The following is a description of a gene set: Cell cycle genes with peak expression in G2/M check point. Cell cycle genes with a CC Expression Score >= 2 (identified in at least 2 genome-wide cell cycle gene expression profiles with peak expression in G2/M) Human Gene Set: FISCHER_G2_M_CELL_CYCLE from publication Fischer M, Grossmann P, Padi M, DeCaprio JA (PMID 27280975) species: Homo sapiens, and this is the list of marker genes: NUSAP1, SLCO1B3, EIF4E, TDP1, TACC3, MID1, KIF18B, H2AZ2, MKI67, CENPL, ADGRG6, UBE2C, MTMR6, CDKN2D, ECT2, SMTN, TNFAIP8L1, CKAP2L, NUP37, SPAG5, POLQ, CDCA2, TTF2, CYP1A1, BCAR3, CENPE, SLC25A24, HMGB2, BRD8, CCNA2, CSPG4, CCNB2, SERTAD3, PPP2R5C, SPA17 (NCBI Gene Id 90953), ARHGEF39, RIN2, GAS2L3, BUB3, CTNND1, CEMIP (cell migration inducing hyaluronidase 1), CIT, KMT5B, TGIF1, NUP98 (NCBI Gene Id 51457), CDR2, PRC1 (NCBI Gene Id 9055), CNTROB, RACGAP1, GIT2, MEAK7, TMPO, CDC25B, BAG3, H2AX, CDC27, CCSAP, TNFAIP2, CFLAR, HMMR, TRIM59, ANP32E, ELK3, KIF2C, DCP2, ARL6IP1, WSB1, AMD1, CDKL5, NUP50, HMGA2, TJP1, CDKN2C (NCBI Gene Id 654235), MAT2A, TSN, DEPDC1 (NCBI Gene Id 55635), KNSTRN, HMG20B (high mobility group 20B), CKAP2, RGS3, KDM6A, JADE2, WEE1, ZNF207, ESPL1, NDC80, PPP1R10, KIF22, TRIP13, HSPA1L, TGFB2, LAMC1, PLK4, BUB1, ZNF587, BMP2, METTL4 (NCBI Gene Id 64863), FAM83D, KCTD9, DZIP3, NEDD4L, RAD21, KIF20B, PNRC2, SAPCD2, STK17B, KIF18A, GPSM2, TTK, TNFRSF21, ADGRE5, ACSL4, ANXA3, FZR1, DBF4B, OIP5, NUMB, CDK1, HJURP, KIF23, TOP2A, UBE2G1, AURKA, PSMD11, KIF11, PLK1, LBR, TROAP, DUSP4, RNF4, TNPO2, CCNF (NCBI Gene Id 899), RDH11, PTTG1, PLAU, GTSE1, DCLRE1C, KIF14, SFPQ, KIF20A (kinesin family member 20A), BIRC5, PBK, TUBD1, BTBD3, CEP350, KATNA1, DNAJB1, ARHGAP11B, SHCBP1, ATF7IP, ARHGAP11A, MELK, PCF11, NIF3L1, FAM110A, KIF5B, CDCA3, CKS2, CDC42EP4, NEIL3, DEPDC1B (DEP domain containing 1B), PLEKHA5, NUF2, CDC20, IQGAP3 (IQ motif containing GTPase activating protein 3), HMGCR, SIX4, NCAPH, CENPA, HP1BP3, EIF2AK3, MPHOSPH9, DR1, PSRC1, VANGL1, FOXM1, GOT1, ZNF614, CEP55, MGAT2, ASPM (NCBI Gene Id 93990), H1-0, ANLN, JPT1, NDC1, MAD2L1, NEK2, CKAP5, ZNF518A, RAD51C, KPNA2, CCNB1, PKNOX1, BUB1B, RSBN1, CDC25C, ZMYM1 (NCBI Gene Id 79830), CDCA8, E2F5, AURKB, BIRC3, DBF4, CDKN1B, ARL4A, BTG1, UBE2S, UBE2D1, LDLR, FYN, PIMREG, NDE1, SAP30, SGO1, TPX2, CKS1B, NUP35, CHEK2, STAT1, STIL, ZNF165, CLK4, FNBP4, CEP70, PIF1, CENPF, HMGB3, NFYB, CABYR, ARHGAP19, KIFC1, NET1, SGO2 (shugoshin 2), KIF15, TUBB, ZNF267 (zinc finger protein 267), FAM3C